The following is a description of a gene set: Mouse Gene Set: GOBP_MRNA_EXPORT_FROM_NUCLEUS species: Mus musculus The directed movement of mRNA from the nucleus to the cytoplasm., and this is the list of marker genes: Thoc6, Magohb, Nxf2, Ddx19a, Alyreffm7, Nup88, Alyreffm1, Thoc7, Nup93, Setd2, Alyreffm11, Nup133, Ddx39a, Nup155, Hhex, Akap8l, Nup85, Ddx19b, Casc3, Fmr1, Alyreffm10, Alyreffm2 (Aly/REF export factor family member 2), Alyreffm9, Poldip3 (polymerase (DNA-directed), delta interacting protein 3), Supt6, Nsun2, Rbm15b, Xpo1 (exportin 1), Wnk1, Nxt1, Nxf7, Nup160, Alyreffm6, Sarnp, Fyttd1, Magoh (mago homolog, exon junction complex core component), Thoc3 (NCBI Gene Id 73666), Eny2, Alyreffm3, Rbm8a, Gle1, Ncbp3, Ddx25 (NCBI Gene Id 30959), Ythdc1, Thoc2, Ncbp1, 1700017N19Rik, Zc3h11a, Srsf3, Mcm3ap, Nxt2, Alkbh5, Eif4e, Alyref, Pcid2, Ncbp2, Iws1, Thoc1 (NCBI Gene Id 72418), Alyreffm5, Nup107, Nxf1, Nup214, Alyref2, Sem1 (NCBI Gene Id 20422), Ddx39b, Hnrnpa2b1, Alyreffm8, Eif4a3, Nxf3, Alyreffm4, Alyreffm14, Chtop, Thoc2l, Tpr, Thoc5, Pabpn1